The following is a description of a gene set: species: Mus musculus Mouse Gene Set: GOBP_POSITIVE_REGULATION_OF_MYOTUBE_DIFFERENTIATION Any process that activates, maintains or increases the frequency, rate or extent of myotube differentiation. Myotube differentiation is the process in which a relatively unspecialized cell acquires specialized features of a myotube cell. Myotubes are multinucleated cells that are formed when proliferating myoblasts exit the cell cycle, differentiate and fuse., and this is the list of marker genes: Rbm24, Cyp26b1, Myog, Mtor, Atp11a (NCBI Gene Id 75344), Maml1, Mamstr, Tbx1, Mapk14 (mitogen-activated protein kinase 14), Cav3, Piezo1, Smyd1, Mmp14, Neu2, Csrp3